Given this list of marker genes IKZF4, CDKN1A, GSTM3, TNFRSF18 (TNF receptor superfamily member 18), SKIL, MIPOL1, CRMP1, DEFB119, PIGO, HINT1, AJUBA (NCBI Gene Id 84962), GRAMD4, MMP9 (matrix metallopeptidase 9), SLAMF1, AREG, PAG1, MARCHF7, GNAQ, NFKB1, ROM1, LRRC49, MGAT4B, GPM6A, INPP4B, SWAP70, NSD3, DSG2, PRXL2A, FBXO17, IQGAP2, PTGER4, C12orf75, PLEC, NEB, N4BP1, MAP6, FBXO30, CCL1, DNAH7, STYX, FOXP3, TAFA3, PDGFD, C3orf18, TGFBR1, SOCS2 (NCBI Gene Id 8835), ARL5B, CAPG, BMP2K, CLINT1, CD99, IL2RA, PROS1, TPT1, TBC1D32, NDRG1, FGL2 (fibrinogen like 2), CTLA4, RPL17, PLEKHG5, LBR, SEPTIN8, SH3BP5, HOMER3, RPL14, DENND5A, CD47, PTPN3, STC2, CD209, MCCC1, PTGIR, RNF128, CNTLN, RXRA, ARNT2, FILIP1L, IL13, LTB4R, APPL1, L1CAM, TRPM4, CCR8, MYADM, FAM107B, NIBAN2, NAGA, EIF4EBP1, SLC44A2, ANAPC5, FNDC8, TSPAN4, AHNAK, SERINC3, AP5M1, SLC22A5, CXCR6, ACVR2A, PPARG, XBP1, KLRK1, PTPRK, CSF2, PLP2, OIT3, PON3, IFITM3, COBLL1, DLG2, CAST, SHE, LGALS3, SLC29A1, FAM20A, PDPK1, KRT18, CASS4, RNASE4, IL1RL1, FNDC10, TUBE1, RHOC, CCR2, TRAF6, NCK2, FN1, ADAM8, ADGRG3, ITGA1, DKKL1, STX1A, HLA-DMA, PIM1, RRAGD, SLC38A2, GPR137B, CSF1, PCMT1, RAPGEF6, RPS6KA5, MATK (megakaryocyte-associated tyrosine kinase), GATA1, NOTCH2, RPS15A, KLK8, KCTD12, AKAP11, IL6, HAPLN1, GABRA4, ITGAE, DUSP11, ENTPD1, ACVR1B, CASTOR1, GPLD1, TMEM273, SLC30A2, SH3BGRL, CCR1, LGALS1, CXCL3, PLA2G6, BMPR1A, EXOSC9, KIF3A, CRYBG2, KLHDC2, AFF1, KAT2B, ITGA6, PLAC8, JCAD, TMEM205, CD79B, PPM1L, SFT2D2, RPS23, IL17RB, KLF11, ECM1, C9orf152, BHMT2, DUSP16, PAQR3, CYSLTR1, SV2C, CNR2, DCTN1 (NCBI Gene Id 82109), DBP, PHETA2 (NCBI Gene Id 150368), CISH, AHR, HRH4, ABHD16A, TMEM64, PRNP, C15orf48, IFITM2, here is a description of the gene set: Human Gene Set: GSE19941_LPS_VS_LPS_AND_IL10_STIM_IL10_KO_NFKBP50_KO_MACROPHAGE_DN from publication Yang HT, Wang Y, Zhao X, Demissie E, Papoutsopoulou S, Mambole A, O'Garra A, Tomczak MF, Erdman SE, Fox JG, Ley SC, Horwitz BH (PMID 21217011) Bone marrow-derived macrophages were produced from mice lacking IL-10 alone (IL10-def) or mice lacking both IL-10 and the p50/p105 subunit of NF-kB (p50/IL10), and left unstimulated, stimulated with LPS (1 ng/ml) or stimulated with LPS and IL-10 (0.3 ng/ml). studied in species Homo sapiens Genes down-regulated in NFKB1 and IL10 knockout macrophages stimulated by LPS versus those also stimulated by IL10.